The following is a description of a gene set: studied in species Mus musculus This event has been computationally inferred from an event that has been demonstrated in another species.<p>The inference is based on the homology mapping from PANTHER. Briefly, reactions for which all involved PhysicalEntities (in input, output and catalyst) have a mapped orthologue/paralogue (for complexes at least 75% of components must have a mapping) are inferred to the other species. part of: Immune System electronically inferred by orthology from the curated human pathway Reactome Pathway: Cytokine Signaling in Immune system, and this is the list of marker genes: Stat4, Psmc2, Irf9, Il10 (interleukin 10), Nkiras1, Crlf1, Eif4e3, Irak1, Tnfsf14, Tslp, Il23a, Psma1, H3c4, Mapk14, Cd70, Grb2, Kpnb1, Ifnar1, Fance, Map3k3, Crk, Il1a, Casp8, Il9, Ppp2r5d, Ifngr1, Flnb, Il27, Map2k7, Ctf1, Psmc1, Vamp2, Map2k4, Psmd13, Ikbkb, Tubb4b, Tnfsf18 (tumor necrosis factor (ligand) superfamily, member 18), Stat5a, Tubb4a, Ltb, Il6, Fnta, Cbl, Il19, Ifng, Lrrc14, Il21, Snca, Jak3, Tnfrsf11b, Nfkb1, Il5ra, Mapk8, Mapk7, Mavs, Ube2d1, Il33, Faap100, Tnfrsf4, Camk2b, Peli2, Tec, Il13ra1, Tab2, Ifna1, Ebi3, Mapk3, Tifa, Dusp6, Ifnb1, Il36a, Psma2, Psmc6 (NCBI Gene Id 67089), Il13ra2, Hspa2, Flt3l, Arih1, Gbp5, Cenps, Il1rl1, Il27ra, Kpna1, Relb, Irf3, Il22, Dusp7, Tnfrsf25, Tnf, Rps27a, Fancg, H3c15 (H3 clustered histone 15), Tnfsf11, Cd40lg, Il18bp, Ifna14, Vav1, Tubb2b, Fyn, Il1r2, Il20, Tuba8, Sdc1, Eif4a1, Tnfrsf1b, Il4, Ppp2r5a, H3c8 (NCBI Gene Id 97908), Lif, Tnfrsf17, Mapt, Rps6ka5, Stx1a, Il2, Eda, Birc3, Ifna16, Psma6, Prkaca, Smarca4, Ppp2r1b, Il18rap, Il12a, Rela (v-rel reticuloendotheliosis viral oncogene homolog A (avian)), Il21r, Ifnl3, Psma5, Il1r1, Nlrc5, Ptpn2, Vrk3, Il23r, Il1f10, Il20ra, Tab1, Uba7, Lta, Ube2n, Psmc4, Ifna15, Inppl1, Myd88, Tnfrsf13c, Map2k3, Nfkbia, P4hb, H3c7, Jun, Psmd7, Psmc3, Osm, Socs3, Il2rg, H3c6 (NCBI Gene Id 319151), Il36b, Eif4a2, Tarbp2, Map2k6, Becn1, Ptpn1, Map3k8, Psmb5, Rnf7, Socs1 (NCBI Gene Id 12703), Il31 (interleukin 31), H3c11, Il2rb, Yes1, Cdk1, Sos2, H3c2, Faap20, Psmb7, Gbp2, Psma7, Ctsg, Il34, Cul1, Traf3, Lck, H3c10, Il3, Psma3, Il24, Il9r, Psma4, Tab3, Tuba1a, Stx4a, Tnfrsf18, Ifna9, Tuba1c, H3c13, Hsp90b1, Brwd1, Tnfrsf1a, Gh, Tnfsf8, Mapk9, Ilf3, Psmb4, Irs2, Ube2v1, Nlrx1, Gsdmd, Nfkb2, Irs1, Hras, Oasl1, Il4ra (NCBI Gene Id 16190), Il10ra, Dus2, Tuba3b, Hmgb1, Ubb, Cd27, Psmd6, Mapk11, Tnfrsf14, Fancb, Npm1 (NCBI Gene Id 18148), Map3k14, Trp53, Cntfr, H3c1, Stx3, Osmr, Tnfsf9 (NCBI Gene Id 21950), Tuba4a, Il11ra1, Psmb6, Ifnl2, Nfkbib, Pik3cb, Ifngr2, Tubal3, Csf2rb (NCBI Gene Id 12983), Casp1, Tyk2 (tyrosine kinase 2), Psmc5, Cenpx, Ptpn6, Ifnab, Il31ra, Socs2, Il12b (NCBI Gene Id 16160), Il6ra, Sla, Csf3, Sh2b3, Tuba1b, Csf1r, Tnfrsf11a, Pik3r2, Tnfsf12, Casp3, Tubb6, Il2ra, Clcf1, Ube2e1, Fancc, Fos, Il15, Ppm1b, Psmd1, Il18r1, Pde12, Il16, Grap2, Syk, Tnfsf13, Ilf2, Sqstm1, Ifi44, Tnfsf15, Cntf, Shc1, Csf2, S100b, Irak3, Psmd12, Sumo1, Ifna4, Csk, Il5, Rigi, Cdkn1b, Il11, Hspa1l, Ifna13, Ager, Ifnlr1, Ifna12, Stat5b, H3c3